Given this list of marker genes Il2rg, Il9r, Stat5a, Il9, Stat3, Stat5b, here is a description of the gene set: species: Mus musculus Interleukin-9 signaling Mouse Gene Set: REACTOME_INTERLEUKIN_9_SIGNALING